Given this list of marker genes THBD, HSPB2, ABCA8, CCL19, FHL1, CD6, GMFG, SELL, CNN1, FAM107A, XCL1, ID1, ABCA6, LAMA2, COL17A1, CYTIP, CD7, CELF2, GIMAP4, LY9, MYLK, C3, IL1R2, KCND3, EFEMP1, OPRPN, CYRIA, PROS1, IGHG1, LST1, KCTD12, LILRB3, FRZB, PLAC8, MT1M, DES, RELN, ADAM28, LYVE1, PIK3R1, MAP4K1, MEOX1, IGKC (immunoglobulin kappa constant), TNFRSF17, POU5F1 (NCBI Gene Id 7934), CAV1, HGF, SYNE3, KLRK1, ALDH1A1, CYP1B1, FLRT2, RGS5, CLEC4A (C-type lectin domain family 4 member A), DOCK10, NRXN1, RASGRP2, IL2RG, THEMIS2 (thymocyte selection associated family member 2), LYL1, SLC6A14, AQP1, CCDC88A, CFH, CD247, GZMM, S100B, ITGA4, NRIP2, BTN3A2, P2RX5, IGLL3P, VNN2, ABCB1, POU2AF1, LAMC3, PNOC, COL18A1, ANGEL1 (NCBI Gene Id 23357), GVINP1, SRPX, SP110, ST6GAL1, BTK, CTSC, RNF125, CDO1, IGLV3-25, TNFRSF1B, IL21R, FMNL1, LINC01140, CRYAB, CORO1A, JCHAIN, HIVEP2 (NCBI Gene Id 3097), SNX1 (sorting nexin 1), GIT2, MAPRE2 (microtubule associated protein RP/EB family member 2), SPINK5, P3H2, CD1E, DCN, CES1, CASP10 (caspase 10), ENSG00000293341, KRT5, APOBEC3G, CCL21, LDHB (NCBI Gene Id 3945), NPR2, ANK2, TRBC1 (NCBI Gene Id 28639), MET, PPP3CC, IGLV3-10, LAMA4, LCK, LYN, MEOX2, HLA-DPA1, LY75, ACKR1, TP63, CLDN5, BANK1, ZBTB20, EMILIN1, NPR1, BIRC3, PDGFD, ICAM2, APLNR, KRT14, PRKCB, CD3G, LEF1, MS4A6A, CD79B (NCBI Gene Id 974), CD74, CYLD, NSG1 (NCBI Gene Id 27065), C1S, LMOD1, CHI3L1, POU6F1, CCR2, ITGA7, TMOD1, PTN (NCBI Gene Id 5764), NCR3, WIPF1, LGALSL, CD22, PAX5, CD4, FYB1, TRAF3IP3, SELENOP, ITM2A, PLCL2, PDE2A, LPL, VILL, STK10, GPR18, EZH1, CCR6, DEPP1, PECAM1, CCL14, HBB (NCBI Gene Id 3043), HHEX (hematopoietically expressed homeobox), F10, RBMS1, GIMAP5, BTN3A3, IL6R, LYZ, TLE4, AOC3, LAMP3, ID3, FCER1A, CD244, NR3C2, DMD, PTGER4, IL7R, DST, SIGLEC1, DPT, FNDC4, FBLN5, ITIH5, HOXA5, SELE, TRBC2 (NCBI Gene Id 28638), CLEC3B, NCKAP1L, MFAP4, DLK1, TNFRSF25, TFPI, LPCAT4, NFAT5, ELMO1, DOC2B, BBOX1, TRDC, LY96 (NCBI Gene Id 23643), C1R, TSPAN7, PACRG, COL14A1, NCF4, TESC (NCBI Gene Id 54997), CCL5, STAG3, PPP2R1B, SPIB, CXCL13, CD38, RAC2, GJA4, RUNX1T1, FCMR, HOXA9, FZD7, TGFBR3, CXCL2, COTL1, ROBO3, GNG11, CMA1, FYN, IFI16, CD69, TIE1, CD27, RIPOR2, IGLC2 (NCBI Gene Id 3538), VAMP5, RUBCNL, CHRNB2, ZBP1, DPP4, IGKV4-1, GZMA, CD52, GZMB, GIMAP6 (NCBI Gene Id 79765), NRXN2, SAA1, SLA, CCDC69, IGLV2-14, ARHGAP45, CD3D, ATP2A3, IL1R1, OXTR, CSGALNACT1, TESPA1, CPE, ACAP1, SATB1, CD40LG, LZTS1, SPRY2, ODAM, MTRF1, PVRIG, CD1D (NCBI Gene Id 912), SRGN (serglycin), HOXA7, NKG7, ANGPT2, LCP2, SLC12A4, ID4, SYNE1, SPARCL1, PDGFRA, PIK3CD (phosphatidylinositol-4,5-bisphosphate 3-kinase catalytic subunit delta), MATN2, CSF2RA, IRF8, RUNX3, VAMP1, RRN3, KIT, CLEC10A, PALMD, NT5E, ZAP70 (zeta chain of T cell receptor associated protein kinase 70), NLRP1 (NLR family pyrin domain containing 1), CXCL12, IRAG2, BIN1, HLA-DOB, IGF1, DDX28, GZMK, CFI, MATK, HLA-DQB1, TCF4, TRGC1, MAST3, PRKCQ, F13A1, DOCK2, ACTA2, ARID5A, CD72, PTPN22, CHL1, PLTP, PCSK5, LIME1, SLC16A7, MAP7D3, IGKV2D-28, MRC1, TXNIP, LHFPL6, ISG20 (NCBI Gene Id 3669), DEF6, CCDC102B, KANK3, MYH11, NCF1, ADARB1, BIN2, NAP1L2, GDF7 (growth differentiation factor 7), FXYD1, AASS, CPVL, GGT5, LRRN3, CD180, LILRA4, CLEC2B (C-type lectin domain family 2 member B), TEP1, EVI2B, PLPP3, ACVRL1, EMCN, IGHM, CYTL1, ADH1B, CD37, RASGRP3, LTB, SNCAIP, GLIPR1, CD2 (NCBI Gene Id 914), CSN3, CD96, CR2, VPREB3, ZEB1, BAALC, ENPP2, DOK2, ARHGAP4, ARHGAP25, SLCO3A1, RNASE6, SIT1, TNXA, PLCB2, KCTD7, LAT, TCL1A, TF, CD302, CIITA, SORBS1, CASP1, ABLIM1, VEGFD, ADGRF5, CXCR5, KRI1, FABP4, CD48, AOAH, PTPRC, PLEKHO1, CD19, ST3GAL2, SLIT3, SFRP1, GEM, IGKV1D-17, BCL11B (NCBI Gene Id 64919), KLRB1, IL27RA, EDN3, FMO2, DLK2, IGKV3-20, ITGB7, SVEP1, STAP1, PRF1, FCRL2, ITGAL, SKAP2, SEL1L3, CLU, GPR183, CTSG, ICOS, VCAM1, IL6, ARL4C, MBP, CRY2, CH25H, C7, MALL, ARHGAP15, NLRP3, CTSW, TRAC, KLK7, SERPING1, LEPR, SYNM, DTNB-AS1, BCL11A, PPP1R16B, ITM2C, CCR7, CD8A, FOXN3, FLI1, PTGDS, ITK, CD1C, MZB1, MGAT3, GMIP, WIF1, NTRK2, IGHD, FLT3LG, SOSTDC1, HLA-DRB1, LGALS2, PELI2, CLIC2, CD40, P2RY14, CCL2, FOLR2, MS4A1, SP140, RASA4, EPHA4, CD79A, IGHA1, AIF1, HLA-DRA, IL33, PLA2G2A, MME, IL18R1, SH2D1A (NCBI Gene Id 4068), MEF2C, TNFAIP8 (TNF alpha induced protein 8), ADD3, ACACB, TRAT1, CDKN1C, CHRDL1, PTPRCAP, LRCH4, GPR171, IL7, here is a description of the gene set: We explored whether the five previously reported molecular subtypes in breast cancer show a preference for organ-specific relapse and searched for molecular pathways involved. The intrinsic gene list describing the subtypes was used to classify 344 primary breast tumors of lymph node-negative patients. Fisher exact tests were used to determine the association between a tumor subtype and a particular site of distant relapse in these patients who only received local treatment. Modulated genes and pathways were identified in the various groups using Significance Analysis of Microarrays and Global Testing. Bone relapse patients were most abundant in the luminal subtypes but were found less than expected in the basal subtype. The reverse was true for lung and brain relapse patients with the remark that absence of lung relapse was luminal A specific. Finally, a pleura relapse, although rare, was found almost exclusively in both luminal subtypes. Many differentially expressed genes were identified, of which several were in common in a subtype and the site to which the subtype preferentially relapsed. WNT signaling was up-regulated in the basal subtype and in brain-specific relapse, and down-modulated in the luminal B subtype and in bone-specific relapse. Focal adhesion was found up-regulated in the luminal A subtype but down-regulated in lung relapse. The five major molecular subtypes in breast cancer are evidently different with regard to their ability to metastasize to distant organ(s), and share biological features and pathways with their preferred distant metastatic site. Genes up-regulated in the normal-like subtype of breast cancer. species: Homo sapiens from publication Smid M, Wang Y, Zhang Y, Sieuwerts AM, Yu J, Klijn JG, Foekens JA, Martens JW (PMID 18451135) Human Gene Set: SMID_BREAST_CANCER_NORMAL_LIKE_UP